Given this list of marker genes Chmp2b, Mvb12b, Uba52, Ubb, Vps28, Stam2, Uba52rt, Chmp6, Snf8, Chmp7, Rps27a, Vps25, Vps37d, Vps37a, Hgs, Tsg101, Stam, Vps4a, Chmp4b, Chmp2a, Chmp3, Ubap1, Vps36, Vps37b, Vta1 (vesicle (multivesicular body) trafficking 1), Vps37c, Chmp4c, Ubc, Vps4b, Chmp5, Mvb12a, here is a description of the gene set: Mouse Gene Set: REACTOME_ENDOSOMAL_SORTING_COMPLEX_REQUIRED_FOR_TRANSPORT_ESCRT species: Mus musculus Endosomal Sorting Complex Required For Transport (ESCRT)